Given this list of marker genes HLA-DRA, HLA-DQB1, FYN, TRAV19, HLA-DRB1, PPP2CA, PIK3R3, HLA-DQA1, CD274, PAK3, HLA-DPA1, PPP2R5C, TRBV12-3, CTLA4, PAK2, SRC, LCK, PPP2R5D, GRAP2, THEM4, AKT3, LYN, CD80, AKT2, MAP3K8, GRB2, TRIB3, MTOR, PPP2R1A, PTPN11, CD28, CD4, MLST8, VAV1, TRAV8-4, MAPKAP1, MAP3K14, TNFRSF14, PPP2R5A, HLA-DQA2, PPP2R5E (NCBI Gene Id 63385), CD3D, HLA-DRB3, PTPN6, TRAV29DV5 (NCBI Gene Id 28653), AKT1, CDC42, BTLA, HLA-DRB5, PDPK1, PIK3CB, PAK1, RAC1, PPP2R1B, PIK3CG, PIK3CA, ICOS, PPP2CB, PDCD1LG2, PIK3R5, CD247, PDCD1, CD3G, PPP2R5B, PIK3R2, YES1, HLA-DRB4, PIK3CD, HLA-DQB2, PIK3R6, TRBV7-9 (NCBI Gene Id 28589), RICTOR, CD3E, ICOSLG, CD86, PRR5, HLA-DPB1 (NCBI Gene Id 3115), CSK, PIK3R1, here is a description of the gene set: species: Homo sapiens Human Gene Set: REACTOME_REGULATION_OF_T_CELL_ACTIVATION_BY_CD28_FAMILY Regulation of T cell activation by CD28 family